Given this list of marker genes AKIRIN1, ATP1B2, PUM2, EDNRA, CECR2, NFATC4, USP33, PICK1, STK25, EZR, SLITRK5, NCKAP1L, MEF2A, PAK2, FNBP1L, PRKCQ, TSC1, EMP1, SLITRK1, KCNQ1, TBC1D22A (TBC1 domain family member 22A), ANOS1, EZH2, CRKL, OSTN, CRK, DNAAF6, CFAP161 (cilia and flagella associated protein 161), ZDHHC17, ULK1, DPYSL5, HMGB1, TRPC6, PRRX1, GK2, DCLK1, PLPPR4, BDNF, FXYD5, ADCYAP1, CNTF, ARPC2, DGUOK, GPM6B (NCBI Gene Id 2824), NTN1, SVBP, SCIN, GRN, IQCB1, CBFA2T2, NGF, POTEKP, CDC42EP5, TCTN2, PDPN, ZFYVE27, PQBP1, DYNLL1 (NCBI Gene Id 8655), ITGA6, DAW1, MYPN, ERICH3, SEMA6B, DNALI1, CAMK2A, PPFIA2, IL15RA, CFAP43, OPHN1, GALNT11, VIM, F2RL1, CCDC28B, DMD, ZMYND12, AP2A1, CEP83, CPNE1, WWTR1, ARTN, STON1, AFG3L2, ODAD2, PTPDC1, ITGA2, TTL (NCBI Gene Id 150465), KLHL1, DTNBP1, DAB2, LIMA1, OTX2, GAS7, MBOAT1, ATMIN, C15orf62, TWF1, GRIN3A, MIR210, CUX2, TULP1, C2CD3, FGD6, PLXNB3, TSPAN2, GPM6A, CCP110, HPRT1, ROBO4, YIF1B, PAK6, KEL, NTRK2, DYNC2I2, STK11, DBNDD2, PLEKHG4B, MIR196A1, TAOK3, PIK3CA, NEU4, PDCL2, VASP, FLRT1, PDLIM5, CNTN6, MNS1 (NCBI Gene Id 55329), SIAH1, DNAL1, HAP1, NMNAT1, SYT3, PTPRH, SLC23A2, TBC1D30, RSPH6A (radial spoke head 6 homolog A), BBS5, RAP2C, SIPA1L1, UCHL1 (ubiquitin C-terminal hydrolase L1), RTTN, SRF, UBXN10, TTLL8, CDH13, CCDC40, CHRNB2, KIF19, MSTN, TBCE, SEMA4C, CC2D2B, UNC5B (unc-5 netrin receptor B), GFY, DLX5, GLI2, VAV2, SEPTIN7, PITPNA, C12orf57, RHOD, CARM1, ITSN2, DZIP1L, TEKT4, BRSK2, STK36, CLN3, LRP2, SEMA5A, MAPK6 (NCBI Gene Id 5597), MCIDAS, TNN, LHX2, PARD3, TMEM67, HDAC6, CCDC66, HYDIN, ANKRD27, CXCL12, RTN4IP1, PTK2B, FEZ2, CWH43, CRPPA, RTN4RL1 (NCBI Gene Id 146760), NREP, OCLN, TOGARAM1, VEGFA, ARHGAP44, APP, CAV1, KIFAP3, EPHA2, KLF5 (KLF transcription factor 5), ITSN1, TIAM2, NEK1, EPO, TAPT1, LYN, TTC29, PIERCE1, CFAP61, CASP3, FN1, EFNA4, EFNB1 (ephrin B1), SPTBN4, PACSIN2, SDK1, OTOGL, IQUB, BRSK1, CCDC78, RHOQ, FOLR1, GATA3, NMNAT3, IMPACT, FLRT3, MECP2, ABHD17B, UST, PTPRG, GPRIN1, LRRC4C, SLC12A5, TBC1D32, CBY1, RAB1A, CAMK1D, DNAH2, PSD (pleckstrin and Sec7 domain containing), KIRREL3, MYO10, ICAM1, CFAP91, FOXJ1, DSCAML1, NEO1, CEP78, SDCCAG8, KIAA1755, FZD3, DNAI1, NDNF, MACF1, NRN1L, CFAP100, CTNNA2, CFLAR, SLC38A8, RFX3, INPP5K, JAK2, ZEB2, MOV10, EFNA5 (NCBI Gene Id 1946), EPHB3, CSPG4, IQSEC1, HES5, LRGUK, TRAF3IP1, BLOC1S4, BAG5, WDR19, TANC2, IFT81, CFAP97D1, MYCBP2, TRIOBP, GORASP1, CRMP1, NRDC, CFAP73, RP2, PTPRM, GDI2, TIAM1, TEKT2, PTN, LHX3, FGFR1, MYO3A, AGRN, ARAP1, HSP90AA1, DNAI3, TOX, MINAR2, CRTAC1, ATAT1, LHX1, CDC42EP3, RAPGEF6, SPOCK1, AK7, LRIG2, ZNF212, GBF1, SCRIB, PTPRJ, NPY, NEDD4, HDAC2, CEP128, ODF2L, FEZF2, TBR1, RAB3A, CSNK1D, PRKCI, STX1B, ARL13A, PTPRT, RRP7A, RAP2B, IFT25, B9D2 (B9 domain containing 2), ODAD4, PTPRK, PTK2, ADGRB1, PTPN1, CEP97, CDH11, BSG, LAMB1, PARD6B, PLPPR5, PIK3R1, SYNGAP1, BCL7A, SLC30A1, PLXNA3, TBX6, RAP1A, RIMS1, TBC1D2B, PLS1, KCTD17, EDN3, GFRA1, NUMB, MAPRE1, AMIGO3, COL25A1, BCL2, RO60, MIEN1, OMG, CPNE6, MICALL2, FBXO7, ADGRV1, ARHGAP24, BHLHA15, S1PR1, TBC1D5, PLEK (pleckstrin), PGRMC1, OLFM1 (olfactomedin 1), TPM1, PPP1R9B, CTNNB1, SFRP2, RAB29, NYAP1, LRRC46, DNAAF3, DIP2A, NTF4, PLEKHM1 (NCBI Gene Id 9842), PIERCE2, PRNP, UHMK1, RAPGEF2, NRTN (NCBI Gene Id 4902), B3GNT2 (NCBI Gene Id 55878), MKKS, INTU, SETX, UNC119B, KALRN, SLC9A6, IFT56, FRMD7, NRP1, KIF21A, ARL13B, SKOR2, LRP8, YAP1, DOCK7, GRXCR2, HERC1, TTC21A, UBB, DNAH7, CFL1, EFHD1, PFN2, FER, RERE, VCL, TCIRG1, MYH10, PCDHAC2, CDC14C, SOS1, CAPRIN1, EDN2, ADAMTS16, MIR200C, GHRL, FLRT2, ONECUT2, YWHAH, PFN1, TSPO, ADARB1, WNT3A, REST, VASH2, VLDLR, TUNAR, TPRN, ABCD2, NDN, ENC1, EVI5L, FAT3, CDC14A, DNAH17, KIF5A, RASGRF1, SMURF1, DYNC2LI1, SEMA6A, ARSB, VIL1, ULK4, AKT1, TTLL1, PLXNA4, MAPT, ENKD1, HTT, EHD2, PARVB, BBOF1, CFAP58, TOR1A (torsin family 1 member A), DYNLT2B, NRXN1, BTBD3 (NCBI Gene Id 22903), MICALL1, EFNA3, WASF2, IQGAP1, DBNL, ISL1, LONRF2, GPRIN3, USP9X, NEDD9 (neural precursor cell expressed, developmentally down-regulated 9), APBB1, EVI5, SMAD4, CCDC38, NTRK3, LPAR1 (lysophosphatidic acid receptor 1), CC2D1A, CTTN, POU4F1, NR4A3, ABI3 (NCBI Gene Id 51225), TENM3, RAB13, DNAAF8, PAX6, POTEF, CCK, CACNG7, BBIP1, KLF7, INPPL1 (NCBI Gene Id 3636), PRAG1, PTPRS, CNTNAP1, NOTCH1, DVL1, SLITRK4, BMPR2, FBXO38, GIT1, MTSS2, PAX2, STAP1, RTN4, KREMEN1, BRK1, SEMA6C (NCBI Gene Id 81604), SHOX2, PAK4, DAAM2, PTPRU, VPS35, ATP6V1D, CDC27, WNT5A, MAP1A, TBC1D10A, RILPL2, NRP2, TBC1D21, ODAD1, EEF2K (eukaryotic elongation factor 2 kinase), TMEM232, CCDC146, SEZ6, SERPINF1, SEMA4B, EHD3, IGF1R, DNAAF11, TBC1D9B, THOC2, PRKD1, DIAPH3, MIR214, EPB41L3, CNTN2, RCC2, RAPH1, OBSL1, GORAB, SH2B1, ATL1, SEMA4G, NEUROD6, SPG11, ADAM17, ELAVL4, SRC (SRC proto-oncogene, non-receptor tyrosine kinase), EPHA6, CEP70 (NCBI Gene Id 80321), KIDINS220, CDH1, GBA1, DAB1, SEMA5B, PLXND1, SMO, STXBP1, DMTN, WASF3, PRDM8, KIF3A, SLITRK6, INPP5J, MAPK8IP2, GLDN, WRAP73, SPAST (NCBI Gene Id 6683), STMN3, TBC1D23, SRGAP2, ACTBL2, ELMOD1, MTMR2, HOATZ, CCDC65, RSPH1, WDR11, NUMBL, BMPR1B, HDGFL3, NOVA2, SF3A2, ENPP2, ZNF804A, DICER1, TPGS1, OFD1, KIAA0319, CEP290, LAMA2, SPATA6, WDR90, NLGN2, LLGL1, RAB11A, CFAP221, IFT172, ROBO2, CAMSAP3, ABCC4, NDEL1, OLIG1, ANKRD24, MIR221, PKD2, DRGX, SNX1, GRM7, IL1RAPL1, NRXN3, PTPRD (NCBI Gene Id 5789), CEP120, S100B, CD3E, MANF, MAP1S, PLEKHG4, CLASP2, FCGR2B, SSNA1, CUX1, AUTS2, SPAG17, TMEM17, CCDC15, POU4F2, RET, CDC14B, EFNB3, RALA, EMP3, NOTCH2, RAB34, NES, GDF7, MAP4K4, ABLIM3, ACP4, TWF2 (NCBI Gene Id 11344), COBL, VPS13B, SYT4, IFT43, TUBB3, UNC5A, IFRD1, MARK4, DDX56, SPATA13, CSPG5, SYT17, TRPM2, CLMN, ADNP, GPRIN2, TNFRSF21, LMO4, PREX2, SEMA3G, ONECUT1, LCN2, FGF8, TBC1D22B, POTEE, AGER, ROPN1B, RIT2, CYLD, LRRC23, IFT80, OR10A4, AMIGO1, CYFIP2, TBC1D15, TRAK2, TCTN1, ALPK1, ATG3, CEP162, PLEKHO1, RNF157, CIBAR1, RAPGEF1, FES, LST1, CHODL, NEUROG2, MYH9, NKX2-1, CDC42EP4, TCHP, TSKU, RPL24, NRCAM, CDKL1, CFAP57, CENPJ, CCDC88A, TMEM216, EPHA8, NEXN, NLGN1, BLOC1S3, SEMA7A, GOLPH3, TRIM67, GAS8, IFT70A (NCBI Gene Id 92104), INPP5F, NEUROD4, TRAPPC14, CEP164, BCL11B, CEP295 (NCBI Gene Id 85459), CNTN1, SCARF1, SAXO1, TTC39C (tetratricopeptide repeat domain 39C), CAMSAP1 (NCBI Gene Id 55490), SCN1B, RGMA (repulsive guidance molecule BMP co-receptor a), CCDC32, DENND5A, SLC39A12, RAB6B, LZTS3, MAGI2, TBC1D19, TRIM32, BAIAP2, BLOC1S2, GFRA3, CLRN2, LTK, PALLD, STRC, BRAF, SEMA6D, TECTA, CFAP20, B3GLCT, TRIP11, ARHGEF25, DNHD1, VAX2, FIGNL2, CFAP263, IGSF9, SEMA3A, ALK, ITM2C, CLUAP1, LRP4, MAG, SHANK1, TMEM108 (NCBI Gene Id 66000), USH1C, EFHC2, PLK5, WASHC1, WASHC5, PJVK, DCDC2, RAB35, CCDC103, PCNT, VAX1, MINAR1, ABLIM2, NEUROG1, ESPN, EPS8L2, NPTN, DLG4, ARHGEF4, APOE, LAMB2, CDK5, OLIG2, SNX2, KIF17, WDPCP, FGD4, B9D1, TBC1D16, BBS4, CFAP53, FYN, PLEK2, ISLR2, EMX1, EPHA5, MAP3K13, TBC1D3, SPAG6, CLRN1, JUN, GOLGA4, GSK3A, STK26, FLOT1, TSC22D4, SPART (spartin), SYT1, DGKG, DCTN1 (NCBI Gene Id 82109), MYO9A, CEP89, YTHDF1 (NCBI Gene Id 54915), ARMC12, SLC25A46, ATG16L1, PKHD1, TUBB2B, ARF4, WNT3, SNAP25, NGFR, IFT57, CDK5R2, METRN, EPHA7, SEMA3B, PLD1, PRKN, MAP1B, IFT122, CARMIL1, WTIP, CELSR3, CFAP44 (cilia and flagella associated protein 44), APLP2, CD38, NEGR1, BHLHE22, ATP1A3, FRY, WASF1, KIF27, TBC1D8, ANK3, CORO1A, TRPC5, ARHGAP33, TEKT1, MYO1A, PLAA, FBXO45, GRXCR1, AJUBA, MNX1, NTN4, CAPZB, EVX1, SEMA3D, ROCK1, UPF3B, AP5Z1, GRIP1, LGI1, CCKAR, FEZF1, SYT2, LGMN, PRKCD, BOC, AHI1, TTBK2, NELL2, CERS2, MARK1, TSGA10IP, PODXL, CCDC63, MEIG1, TTC8, ATOH7, TNIK, ROPN1, GAK, SPEF1, CPNE5, FSCN1, ABITRAM, UCN, CFAP206, ARHGEF26, MCF2, MIR133B, ZNF296, CCDC57, PPP1R12C, STRN, KLC3, NEFL, DNM2, BMP5, PPP2R5B (protein phosphatase 2 regulatory subunit B'beta), MIR219A1, STX3, ANLN, ABLIM1 (NCBI Gene Id 3983), EP300 (E1A binding protein p300), MIR21, MYOT, CCDC39, ARHGEF28, SLITRK3, NTF3, SHOC2, ARL3, TENM2, CYFIP1, EFNB2, POC1A, SYNE2, NEUROD1, EPHB1, CD2AP, DRC1, LHX9, TUB, POTEI, CAMSAP2, RSPH9, ANAPC2, MYO9B, ZNF335, TBC1D13, NDP, PTCH1, SRCIN1, GLCE, NEUROG3, DHX36, KNDC1, ELMOD3, RTN4R, RABGAP1, ANKRD1, POSTN, ILK, GPRASP3, EFNA1, KCNF1, ATP9A, ARX, WNT7B, MKS1, SKIL, ENAH, EPS8L3, SOD1, EXOC5, TENM1, BBS2, NYAP2, CFAP184, SEMA3F, RAB5A, TMEM237, PDCL (NCBI Gene Id 51420), HECW1, IFT22, CDK16, CAPRIN2, NDRG4, TRAPPC4, ENTR1, RAC3, SPACA9, MDM2, FGD3, CFAP54, RAB11FIP3, DVL2, RIMS2, EPHA3, TOP2B, VSTM5, UBE2B, RPGRIP1, ALKAL1, IFT52, BORCS7, DNAAF4, CHN1, ARHGEF6, MICOS10-NBL1, HRG, INSR, LYPLA2, CEP350, ACTR2, BMP7, CREB1, ABCD1, KIF20B, NKX6-1, CIMAP3, CRABP2, GLI3, NR4A2, SULT4A1, ALS2, TRIO, CDKL5, CNP, GBX1, FKBP4, MUL1, KIF24, BBS7, OCRL, ATP7A, NPHP1, SPAG16, NOTO, TREM2, EPHB6, SPAG1, MPHOSPH9, PICALM, DNAI4 (NCBI Gene Id 79819), CDHR5, GPR37, PLXNB2, SDC2, IQCG, PTPN23, VANGL2, PACSIN1, MYO16, ATF1, PTPRZ1, RNF6, RFX4, KIF3B, CFAP157, CAPG, BICDL1, KIF5C, SHH, MAK, P3H1, NTNG1, MAP2K2, CLSTN3, ABL2, RIPOR2, CCDC42, SFRP1, EPS8, CEP43, RABL2B (RAB, member of RAS oncogene family like 2B), PRICKLE1, KLF4, FHDC1, PPP1R12B, EDN1, CCDC88C, ZPR1, TAOK2, B4GALT5, LUZP1, TLX2 (NCBI Gene Id 51407), TMEM231, ADCY6, SGK1, ASAP1, NPHP3 (NCBI Gene Id 27031), IFT20, CCDC13, RPS6KA5, RPGRIP1L, SH3BP1, CEP19, DNM3, TESK1, POU4F3, LRP12, RAB8A, CDK10, P2RY12, MAP4, DHFR (dihydrofolate reductase), HES1, ALKBH1, MDK, GSN, PRKCZ (NCBI Gene Id 5590), KANK1, KAT2B, MYO3B, TBC1D2, DNAH1, RETREG3, RHOG, MEGF8, AIF1L, FEZ1, TMEM138, EMB, WHRN, NFE2L2, SEMA4F (NCBI Gene Id 9408), MYLK, ERCC6, TSGA10, FBXO24, MTR, NCKIPSD, USH1G, NIN, CEP131, DRAXIN, PLXNA1, SERPINI1, DAG1, DRC7, CNR1, DHFRP1, SPG21, CDC42, CFAP46, NTN3, CSF1R, EHD1, SPRY3, FOXB1, CTNND2, DCC, ITPKA, NTRK1, TEKT5, APC, TMEM30A, GBX2, IFT88, GSK3B, LAMA1, WAS, TBC1D17, AVIL, PTEN, GDNF, NOG, PALM, SYT14P1, NPR2, NRN1, SH3GL2, FUT9, LRRC56, ACTB, BAG4 (NCBI Gene Id 9530), LRRC61 (NCBI Gene Id 65999), TGFBR1, FUZ, NMNAT2, AIF1, ITGB1, ATP6V0D1, EXT1, PLA2G10, ARHGAP4, CAMK2G, ARFIP2, EPHB2, CFAP298, ARMCX5-GPRASP2, ARHGEF40, DNAH8, KCNJ10, PARVG, TGFB2, CTHRC1, EPS8L1 (EPS8 signaling adaptor L1), STMN4, CUL7, RAP1B, RPGR, VPS54, NFIB, PIBF1, SAMD14, KIT, INPP5E, ARHGEF7, SPEF2, PDGFA, NTNG2, FGD2, ANO6, MAP6, ABI2 (NCBI Gene Id 10152), NOTCH3, BTG2, TRIM46, TBC1D10B, HOXA2, DNAH5, SRGAP2C, PHPT1, ATOH1, SCLT1, MIR30B (microRNA 30b), AREG, S100A9, CEP20, FAM161A, CPNE9, PSEN1, FZD1, SEMA4A, PTPN11, SNX10 (sorting nexin 10), IFT74, SIN3A, BBS12, DVL3, ITGA1, PLCE1, UNC5C, PHACTR1, FSIP2, BLOC1S5, AURKA (aurora kinase A), GPR22, FOXG1, RABEP2, CD44, OLIG3, ATP8A2, TBC1D14, DNAJB13, CELSR2, ADCY1 (NCBI Gene Id 449484), MEF2C, CDH23, PTPRO, LCA5, SPP1 (secreted phosphoprotein 1), ABL1, APBB2, CEP41, VPS13A, ALKAL2, DSCAM, UBE4B, ARMC2, DYNC2I1, CEP126, TCTN3, NEDD4L, IFT70B, CDC42EP1 (CDC42 effector protein 1), PPP1R12A, ARHGAP35, HRAS, CCDC61, NCDN, GMNC, TNC, KIF13B, TEKT3, RREB1, NECTIN2, APOD, PRKCA, ARC, APLP1, USP6NL, NCK1, PTPRF (protein tyrosine phosphatase receptor type F), PMP22, WDR35, STMN2, CCR7, TPBG, RFX2, ACTG1, SEMA3E, MFSD2A, FSHR, CEP250 (NCBI Gene Id 11190), LCA5L, ADORA2A, RTCA (RNA 3'-terminal phosphate cyclase), KIF26A, ARPIN, ITGA4, KIF5B, FRYL, MAP2K1, KIAA0586, KATNB1, ARF1, TNR, ITGA3, L1CAM, ALCAM, MCRS1, MARK2, RAB25, ST8SIA2, ITGB4, CFAP410, PAK1, CIB1, KHDC3L, NUP85, CDHR2, RAB8B, FSTL4, VDAC3 (voltage dependent anion channel 3), SCARB2, FAM98A, DOCK11, TTYH1, MYO7A, TGFB3, MAPK8IP3, CX3CL1, SPAG9, DNAAF2, EFNA2, LIMK2, RHOA, FGFR2, ITGA8, SEMA3C, TNXB, ERMN, HMCN2, NCAM2, LMX1A, ZMYND8, PRMT1, ADCY10, INS, LIMK1, BCL11A (NCBI Gene Id 55085), DEUP1, DNAH9, RAB3IP, NFASC (NCBI Gene Id 23114), NCKAP1, PRKG1, DUSP23 (dual specificity phosphatase 23), TMEM107, PPP1R35 (protein phosphatase 1 regulatory subunit 35), SEMA4D, HOMER1, RYK, NCS1, RAB23, CATIP, TRAK1, PTK6, MGARP, KIFBP, DIP2B, NDUFAF2, USP17L2, RAB6A, NBL1, KIFC2 (kinesin family member C2), SGSM3, MTOR, TMEM106B, NCK2, FIG4, DRD2 (NCBI Gene Id 91906), MAP2, SLC11A2, STMN1, SLITRK2, VAPA, CUL3, FBXW8, BMPR1A, S100A6, SH3YL1, SEC24B, STAU2, CNTNAP2 (NCBI Gene Id 26047), FARP1, RP1L1, CDK5R1, CEP135, TRPV4, ODF2, NCAM1, LPAR3 (NCBI Gene Id 23566), STK24, LHFPL5, NECTIN1, TTC21B, ZMYND10, DNAAF1, TUBA1A, PHGDH, PLP1, WNT7A (Wnt family member 7A), RAC2, POTEJ, GFI1, RUFY3, BARHL2, SS18L1, ISL2, PTPN9, BHLHE23 (NCBI Gene Id 128408), PAQR3, CARMIL2, CNTROB, GAP43, CHRNA7, UNC13A, CFAP74, CDC20, CC2D2A, JHY, E2F5 (E2F transcription factor 5), BLOC1S1, CROCC, PARP6, S1PR2, NME8, CFAP69, ROBO3, EVL, CCL19 (C-C motif chemokine ligand 19), RILP, DISC1, C21orf91, MYOC, IST1, FBF1, TXNDC15, ACTL6B, FAM161B, DDR1 (discoidin domain receptor tyrosine kinase 1), NR2E1, DKK1, NME7, PLA2G3, GRID2, DDR2 (NCBI Gene Id 4921), WHAMM (WASP homolog associated with actin, golgi membranes and microtubules), BLOC1S6, IFT27, EMP2, TRPV2, BBS9, POC1B, CLCN4, TBC1D31, EPHA4, SLIT1, RB1 (NCBI Gene Id 92728), PAK3 (NCBI Gene Id 5063), RAC1, DCX, TMEM80, PRICKLE3, FMR1, TNFRSF12A, GAREM2, SCN11A, SSX2IP, MMP2, HECW2, EPHA10, FOXD1, CFAP126, SPRY2, BBS1, IL2, MATN2, ZDHHC15, KIF1A (kinesin family member 1A), CNTN5, UNC5D, DEF8, TBC1D20, CHRNA3, NSMF (NMDA receptor synaptonuclear signaling and neuronal migration factor), TBC1D7, SNX3, RND2, NUDCD3, SDC4, ARMC9, PAFAH1B1, NME5, NEURL1, ARF6, B4GALT6, POU3F2, ATCAY, NLGN3, CAMK1, PFN4, NPTX1, ARL6, CCDC159, MAP7D2, FGD5, PARVA, ACAP3, PDZD7, GRIN2B, FAM110C, CDKL3, SNAPIN, IGF2BP1, PREX1, DNAAF10, ADGRF1, KAT2A, WEE1, EGR2, TBC1D24, RASAL1, IFT140, ERBB2, FMNL3, RP1, CFAP47, SZT2, APOA4, FAM149B1, PTK7, TUBD1, NHERF1, GFAP, B4GAT1, EHD4, MARCHF7, CPLANE1, KLK8, RAB21 (RAB21, member RAS oncogene family), FLNA, GALR2, NR2F1, EIF2AK4, LLPH, MIR431, FGD1, IL6, GDI1, CFAP65, PKN2, DNAAF5, RILPL1, PPP1R9A, RELN, PIP5K1A, GPX4, ETV1, RAB17 (RAB17, member RAS oncogene family), B2M, ECE1, DZIP1, BBS10, IFT46, MAPK15, CEP152, MTSS1, NUBP1, CORO1C, CSMD3, CILK1, ARFGEF1, SMAD1 (NCBI Gene Id 4086), CDC42EP2, FOXO6 (NCBI Gene Id 343552), DLG5, ARK2C, E2F4 (E2F transcription factor 4), NUBP2, CFAP119, NEUROD2, PLXNB1, GPC2, CCNO, CDNF (cerebral dopamine neurotrophic factor), CCL21, DNMBP, CTNNA1, LRRC7, HYLS1, VAV3, CPEB3, AKAP4, WASL, RTN4RL2, SNAP29, ANO1, DNAI2, PCM1, XK, ODAD3, ACTN2, KIAA0753, TANC1 (NCBI Gene Id 85461), UGT8, DYNC2H1, CORO1B, WDR47, ACTR3, TBC1D10C (NCBI Gene Id 374403), ROBO1, ABI1, SARM1, ATG5, CDH4, ATXN10, CHL1, SEPTIN2, TTC12, VRK1, P2RX4, CLXN, LAMA5, FZD4, PLEKHA1, SHANK3, TACSTD2, DBN1, STYXL1, RGS2, MACIR (NCBI Gene Id 90355), TTLL3, MINK1, KLK6, CAMK2B, DOCK10, DPYSL3, CPLANE2, BIN3, ACTL8, MT3, CNTN4 (NCBI Gene Id 53943), QRICH2, FGF13, PROM2, SLIT3, C9orf72, PHOX2B, ADGRB3, NGEF, DAB2IP, TTLL5, WNT1, PLK4, MAPKAPK5, ZNF365, PPP1R16B, TTC17 (tetratricopeptide repeat domain 17), TBC1D1, PLXNC1, SDCBP, CFAP70, NKX2-8, RAP1GAP, KDM1A, CIBAR2, MIR222, THY1, LHX4, WDR44, LZTS1, SEPTIN9, ATP8B1, ULK2, RSPH4A, SLIT2, P2RX7, PPP3CB, MYLIP, NEFH, SHTN1, PRDM12, LRRK2, RDX, LGR6, RAP2A, RAB10, PPP3CA, here is a description of the gene set: Human Gene Set: GOBP_CELL_PROJECTION_ORGANIZATION A process that is carried out at the cellular level which results in the assembly, arrangement of constituent parts, or disassembly of a prolongation or process extending from a cell, e.g. a flagellum or axon. species: Homo sapiens